The following is a description of a gene set: Human Gene Set: GOBP_NEURAL_TUBE_PATTERNING The regionalization process that regulates the coordinated growth that establishes the non-random spatial arrangement of the neural tube. species: Homo sapiens, and this is the list of marker genes: FGF8, SOX17, TCTN1, WNT1, IFT140, GLI3, PTCH1, ATP6AP2, EN1, BMP4, KDM2B, ARL13B (NCBI Gene Id 200894), GSC, DZIP1L, SSBP3, GPR161, SHH, SMO, TMEM107, PAX7, WDR19, RNF220, HES1, WNT3A, GBX2, PSEN1, PAX6, TULP3, FKBP8, BMI1, TRAF3IP1, TBC1D32, FOXA1, RPGRIP1L